The following is a description of a gene set: studied in species Mus musculus Any process that decreases the rate, frequency, or extent of lipoprotein particle clearance. Lipoprotein particle clearance is the process in which a lipoprotein particle is removed from the blood via receptor-mediated endocytosis and its constituent parts degraded. Mouse Gene Set: GOBP_NEGATIVE_REGULATION_OF_LIPOPROTEIN_PARTICLE_CLEARANCE, and this is the list of marker genes: Il19, Apoc1, Lrpap1, Abcc8, Apoc2l, Apoc3, Apoc2 (apolipoprotein C2), Pcsk9, Mylip, Khsrp, Ldlr, Csk